Given this list of marker genes Gja1, Gjc2, Gja4, Gjd2, Gje1, Gjb6, Gjb2, Gja6, Gjb3, Gjc3, Gjd4, Gja8, Gjb5, Gjb4, Gja3, Gjb1, Gja10, Gjd3, Gjc1, Gja5, here is a description of the gene set: Mouse Gene Set: GOCC_CONNEXIN_COMPLEX species: Mus musculus An assembly of six molecules of connexin, made in the Golgi apparatus and subsequently transported to the plasma membrane, where docking of two connexons on apposed plasma membranes across the extracellular space forms a gap junction.